Given this list of marker genes Kdm6a, Kmt2d, Rbbp5, Kdm6b, Ash2l, Dpy30, Pagr1a, Ncoa6 (nuclear receptor coactivator 6), Wdr5, Uty, Paxip1, Kmt2c, here is a description of the gene set: studied in species Mus musculus A protein complex that can methylate lysine-4 of histone H3, and which contains either of the protein subunits MLL3 or MLL4 in mammals, or equivalent in other species. Mouse Gene Set: GOCC_MLL3_4_COMPLEX